The following is a description of a gene set: Mouse Gene Set: GOBP_POSITIVE_REGULATION_OF_INSULIN_SECRETION studied in species Mus musculus Any process that activates or increases the frequency, rate or extent of the regulated release of insulin., and this is the list of marker genes: Sox4, Gcg, Capn10 (NCBI Gene Id 98655), Glul, Plcb1, Oga, Prkcb, Cftr, Trh, Ghrl, Camk2n1, Nnat, Serp1, Agt, Myrip (myosin VIIA and Rab interacting protein), Aacs, Stx4a, Slc2a2, Pla2g6 (NCBI Gene Id 53357), Ppard, F2, Prkce, Gna11, Mpc2, Tcf7l2, Gpr39, Trpm2, Lrrc8a, Tm7sf3, Glud1, C1qtnf12, Nr0b2, Ffar2, Rbp4, Gpld1, Gipr, Trpc1, Abcg1, Mlxipl, Pck2, Nkx6-1, Gip, Itpr1, Dynll1, Prkn, Prkar1a, Isl1, Rfx6, Casr, Ano1, Glp1r (glucagon-like peptide 1 receptor), Lrp1, Hnf1a, Vsnl1, Hcfc1, Rph3al, Sirt3, Bad, Abat, Osbp, Trpm4, Rapgef4, Mcu, Abcc8, Nlgn2, Ncoa6, Oxct1, Cask, Ptbp1, Lepr, Pfkfb2, Stim1, Slc30a8, Hif1a, Gja1, Gck, Kif5b, Rac1, Tardbp, Pfkm, Blk, Gnas, Psmd9, Sirt1, Nadk, Gpr68, Prkaca, Anxa7, Cacna1d, Sybu, Gpr27, C2cd2l, Adcy8, Ucn3, Tunar, Crh, Doc2b, Jak2, Atg7, Trpm5, Snap25, Myh9, Bglap2, Ffar1, Chrm3 (cholinergic receptor, muscarinic 3, cardiac), Gnaq, Trpa1, Arrb1, Pdx1, Gper1 (NCBI Gene Id 76854), Nr1h4, Gprc6a, Ppp3cb, Baiap3, Sirt6, Acsl4, Cd38, Orai1, Irs2, F2rl2, Fto, Cacna1c